Given this list of marker genes WTAP (WT1 associated protein), LRRFIP1, SH3BGRL3 (SH3 domain binding glutamate rich protein like 3), PYHIN1, CCZ1B, IRX3, NUAK1, MAN2C1, MKNK2, SNORA28, HAVCR2, ATP1B1, CTSL, P2RY2, PGM2L1, TENT2, FCER1G, SLCO3A1, TLR3, NOD1, RANBP2, ZNF518A, CEP350, FAM13A, SIRPB2, ZNF148, SNX18, SLK, KMT2E, SOCS6, VGLL4, CEP104, TTF1, RAB5B, THUMPD3, HNRNPA1L2, NUDT18, SWSAP1 (SWIM-type zinc finger 7 associated protein 1), KRT8P12, S100A4, CISD3, TRMT2B, GCH1, PRF1, AKAP5, GDAP2, MS4A7, MCHR1, SNTB2, ZNF80, BATF3, METRNL, IL18R1, TSC22D2, CFL1 (NCBI Gene Id 1072), NEK1, IGF2BP3, VCAN, TGFBR3, FBXW11 (F-box and WD repeat domain containing 11), DNAAF9, ATF7IP, TUBA4A, WAC-AS1, PGP, FBXW7, S1PR5, ATP2B1, KATNAL1, KIF21A, FBXW12, CERT1, RAB1B, LATS2, BICRAL, ZCCHC17, ZNF501, IRAK4, MAFB, CCL4, ATG12, TMEM106A, SESTD1 (SEC14 and spectrin domain containing 1), GZMB, RAP1B, TRA2A, RNPC3, DUSP5, LILRB1, CREG1, MORN2, RASSF1, DUSP6, NR4A2, RBBP5, ADGRG1, EHHADH, PIGT, ADRB2, MAF, CD244, PHETA2, CMKLR1, PCNX1, SCAMP4, EIF1, EGR1, DNAJB14, RNF115, C6orf62 (NCBI Gene Id 81688), SDHAF4, CEP78, ZEB2, ZNF264, VPS53, DICER1, BCAT1, MDM2, LRRC75A (NCBI Gene Id 388341), SH2D2A (NCBI Gene Id 9047), ATP2B4, CYBB, BHLHE40, SMURF2, DMAC2L, FAM228B, ZNF562, DSE, BLVRA, PTGER4, ELF4, UBXN7, CLOCK, LARS1, SHOC2, ACTR2, SLC2A6, PDE4A, DUSP10, NKG7, ZBED6, PML, ANKRD17, SESN2, LINC02724, TESK1, PSTPIP2, RHOU, YIPF6, ELOB, NSL1, IL10RA, HIP1, TNRC6B, SYT11, GPATCH2L, DSTYK, CREBRF, SERPINB1, AP5B1, CYP1B1, YIPF3, C1orf174, KDM5A, ITPRIPL2, PHF20, MBD3L1, CSF1R, C1orf21, AFG2A, CPXCR1, UPP1, MIA2, WSB1 (WD repeat and SOCS box containing 1), FANCL, GPATCH2, LAPTM5, ZNF683, PDCD7, TRIM23, FGD4, GOLIM4, PAPSS2, C2orf74, PAK2, ABCG2, ERP44, KLRC3, RAP2A, BCAP29, RASSF4, FAM9B, RUNX3, here is a description of the gene set: species: Homo sapiens from publication Macagno A, Molteni M, Rinaldi A, Bertoni F, Lanzavecchia A, Rossetti C, Sallusto F (PMID 16717116) Genes up-regulated in monocyte-derived dendritic cells: LPS (3h) versus LPS and LPS like antigen from O. planktothrix (3h). A cyanobacterial LPS antagonist prevents endotoxin shock and blocks sustained TLR4 stimulation required for cytokine expression. We report the identification and biologic characterization of an LPS-like molecule extracted from the cyanobacterium Oscillatoria Planktothrix FP1 (CyP). Human Gene Set: GSE4748_LPS_VS_LPS_AND_CYANOBACTERIUM_LPSLIKE_STIM_DC_3H_UP